The following is a description of a gene set: from publication Jeffrey KL, Brummer T, Rolph MS, Liu SM, Callejas NA, Grumont RJ, Gillieron C, Mackay F, Grey S, Camps M, Rommel C, Gerondakis SD, Mackay CR (PMID 16474395) species: Homo sapiens Genes up-regulated in comparison of dendritic cells (DC) versus NK cells. In the present study we used Affymetrix oligonucleotide microarrays to produce gene transcription profiles for the major leukocyte types in humans. This comprehensive dataset enabled us to not only establish which genes were expressed in each leukocyte type, but also which genes were expressed in each subset after activation. The used of a comprehensive dataset of gene profiles from all the major human leukocyte subsets enabled a novel and powerful means for identification of genes associated with single leukocyte subsets, or different immune paradigms. Human Gene Set: GSE3982_DC_VS_NKCELL_UP, and this is the list of marker genes: TRIO, SLC31A1, GPD1, CTSZ, SSR3 (NCBI Gene Id 6747), HIVEP3, SMCO4, APP, ASB13, CENPE, PPP2R3A, IL13RA1, NDRG2, MAOA, CHST7, EIF4E2, CCL22 (C-C motif chemokine ligand 22), SOCS1, FKBP15, AOPEP, VPS41, HPCAL1, CSTB, NANS, PDGFC, NCBP1, AK4, PCDHA10, SLC31A2, H1-0, LAMP1, ANXA2P1, ALOX15, FCER1A, PTGS1, LGALS3, TAB2, SPARC, CLN8, MRPL13, PIR, DTX4, PODXL, TACSTD2, CPEB1, CHI3L1, CD9, VDR, KMO, PRDX3, HLA-DRB1, MITF, FPR3, SLC1A4, HSBP1, NRP1, RAB20, P4HA2, TNS1, CASP6, CTSH, CSF1, ENC1, SCPEP1, MMP9, ITSN1, BSCL2, ASPH, PPP1CC, TREML2, PPP1R3D, ADORA2B, SRPRB, FHL2, PEA15, USP32, RGCC, GPER1, DIAPH2, TOR3A, EML4, SCARF1 (NCBI Gene Id 8578), SIL1, PTK2, MDH1, CCDC88A, CDKN1A, BCAT1, DRAM1, TRAF3, ANPEP (alanyl aminopeptidase, membrane), SEC23B, MKLN1, CBR3, PSMD12, PABPC4, TBC1D8, UTP3 (NCBI Gene Id 57050), RAB11A, CREB5, ACOX1, RENBP, ALAS1, CTTN, ESD, LRRC32, RBM47, FN1, ABHD6, MCUR1, DYNC1I2, PPARG, NR4A3, BEX3, ATP5MC3 (ATP synthase membrane subunit c locus 3), PYY, DHRS9, ARHGAP22, STXBP1, TST, ADAM12, CLU, SPINT1, MRAS, KCNJ1, PPM1H, MYBPC2, SLCO2B1, CD83, IGSF6, MMP19, CCNA1, NPR1, SHB, SCD, CCNH, PTCD1, CYP4F8, H2AC6, SNX13, NTAQ1, MRPL42, ATP6V1H, IQSEC2, SGK1 (NCBI Gene Id 6446), GUCA1A, TAL1, TUBA4A, ATF3, TFDP3, CPPED1, HLX, SLC47A1, VPS37C, H2AC17, PDLIM4 (PDZ and LIM domain 4), PTRH2, METTL8 (NCBI Gene Id 79828), FOSL1, IL1RN, PFKP, NPL, RAD1, NQO1, GM2A, CTNNAL1, PGLYRP1, ADM, GSN, CLTC, ARL4A, CYB5R3 (cytochrome b5 reductase 3), GGCT, NLGN3, SLC19A1, FTH1 (NCBI Gene Id 92182), CTNS, AMPD3, JUP, CERS6 (NCBI Gene Id 253782), CD1E, AKR1A1, RAB23, CCL1, NFKBIE, ARHGEF10L (NCBI Gene Id 55160), FSCN1, MIEF1, FCGR2B, CLPB, CLDN17, NOL3, CYP27B1, TMEM53, TNIP1, GSS, CDC42BPB, MAGOHB, RAB31, CAT